The following is a description of a gene set: studied in species Homo sapiens The purine ribonucleotide inosine 5'-monophosphate (IMP) is assembled on 5-phospho-alpha-D-ribose 1-diphosphate (PRPP), with atoms derived from aspartate, glutamine, glycine, N10-formyl-tetrahydrofolate, and carbon dioxide. Although several of the individual reactions in this sequence are reversible, as indicated by the double-headed arrows in the diagram, other irreversible steps drive the pathway in the direction of IMP synthesis in the normal cell. All of these reactions are thus annotated here only in the direction of IMP synthesis. Guanosine 5'-monophosphate (GMP) and adenosine 5'-monophosphate (AMP) are synthesized from IMP. Reactome Pathway: Purine ribonucleoside monophosphate biosynthesis part of: Nucleotide biosynthesis, and this is the list of marker genes: ADSL, ATIC, IMPDH1, PFAS, GMPS, IMPDH2, ADSS1, PAICS, PPAT, ADSS2, GART